Given this list of marker genes ITGB3, NECTIN3, CLDN1, VAV2, TLN1, PDGFB, PDGFRB, CDH1, IQGAP1, RAP1A, RAPGEF1, RAP1B, ITGAV, AFDN, PVR, NECTIN1, PTPRM, PIK3R1, PIK3CA, PIP5K1C, CDC42 (NCBI Gene Id 998), FARP2, CTNNB1, RAC1 (Rac family small GTPase 1), CRK, F11R, SRC, PTK2, NECTIN2, CTNNA1, here is a description of the gene set: Human Gene Set: PID_NECTIN_PATHWAY Nectin adhesion pathway from publication Schaefer CF, Anthony K, Krupa S, Buchoff J, Day M, Hannay T, Buetow KH (PMID 18832364) species: Homo sapiens